The following is a description of a gene set: from publication Chen Y, Wang X (PMID 31504780) Mouse Gene Set: MIR_470_5P studied in species Mus musculus Genes predicted to be targets of miRBase v22 microRNA mmu_miR_470_5p in miRDB v6.0 with MirTarget v4 prediction scores > 80 (high confidence targets)., and this is the list of marker genes: Ube2q1, Atp2a2, D430041D05Rik, Stk35, Tardbp, Adamts6, Bnc1, Dnajc6, Deptor, Cxcl13, Inafm2, Jmjd1c, Nf1, Denr, Bdnf, Npm1, Nhp2, Trpm3, Hmbox1, Srp54c, Camta1, Ppp1r3d, Antxr1, Phf20l1, Emp2, Notch1, Aldh1a1, Fam107b, Cnot6, Calb1, Dnajb9, Spred3, Oxgr1, Men1, Sertad4, Gfra4 (NCBI Gene Id 99308), Eif4g3, Cstf2, Gtf2e2, Stk38, Gdpd1, Lypd6, Nfat5, Emx2, Frmd4a, Mup5, Rabgap1l, Lin7c, Rassf2, Mmp14, Mks1 (MKS transition zone complex subunit 1), Nr1d1, Ms4a7, E2f3, Frmpd4, Olfm1, Bcl7a, Sema3d (sema domain, immunoglobulin domain (Ig), short basic domain, secreted, (semaphorin) 3D), Kctd12, Nrip3, Adarb2, App, Uty, Krtap8-1, Pomt2, Isl2, Creb5, Ube2d1, Ptprm, Erbb4, Cyp2b23, Cd47, Dscaml1, Igsf6, Mup4, Rit2, Gm904, Obsl1, Tmcc1, Fam81a, Terf2 (telomeric repeat binding factor 2), Ubp1, Cideb, Cplane1, Rab2a, Gpr174, Gas1, Exo1, Tmem220, Tgif1, Picalm, Ppp1r2, Ppp6r3, Onecut2, Ror1, Afdn, Srp54a, Ppp4r2, Xirp2 (xin actin-binding repeat containing 2), Il7, Dlc1, Adora2a, Smarca2, Ncl, Casp7, Antxr2, Gga2, Srp54b, Tmem98, Tent2, Mbnl2, Cdk14, Ago1, Smc2, Abraxas2, Edn1, Dgcr2, Ints7, Ogn, Il20, Grm7, Eva1a, Copg2, Apobec1, Itga4, Arpp21, Dld, Fpgt (fucose-1-phosphate guanylyltransferase), Fancm, Grm1, Zdhhc17, Syt14